Given this list of marker genes Stab2, Apob, Sparc, here is a description of the gene set: This event has been computationally inferred from an event that has been demonstrated in another species.<p>The inference is based on the homology mapping from PANTHER. Briefly, reactions for which all involved PhysicalEntities (in input, output and catalyst) have a mapped orthologue/paralogue (for complexes at least 75% of components must have a mapping) are inferred to the other species. Reactome Pathway: Scavenging by Class H Receptors part of: Binding and Uptake of Ligands by Scavenger Receptors species: Mus musculus electronically inferred by orthology from the curated human pathway